Given this list of marker genes Adcy8, Ppp2r2a, Ppme1, Mapt, Bod1, Rps6kb1, Ptpa, Sphk1, Ensa, Trp53, Hmgcr, Cacna1b, Pabir1, Mfhas1, Smg7, Mastl, Stat1, Dab2ip, Akap6, Cttnbp2nl, Cpd, Ankle2, Shc1, Foxo1, Eif4ebp1, Vim, Ppp2ca, Strn3, Igbp1b, Strn4, Ptpn1, Bcl2, Smg5, Akt1, Igbp1, Gna12 (guanine nucleotide binding protein, alpha 12), Strn, Grin3a, Cacna1c, Slc6a3, Arpp19, Adrb2, here is a description of the gene set: Binding to protein phosphatase 2A. species: Mus musculus Mouse Gene Set: GOMF_PROTEIN_PHOSPHATASE_2A_BINDING